The following is a description of a gene set: from publication Miyazawa M, Takashima A (PMID 22974541) Genes up-regulated in dendritic cells: 2,4-dinitrofluorobenzene (DNFB) versus diphenyleneiodonium (DPI). Identification of ROS induced genes on dendritic cells Dendritic cells were incubated for 15 min with or without a ROS inhibitor (DPI), washed extensively and incubated for 30 min with a chemical allergen (DNFB), hydrogen peroxide, and vehicle alone in HBSS containing DPI or vehicle. After washed extensively, the samples were post-incubated for 5.5 h with DNFB, hydrogen peroxide, or vehicle in complete culture medium containing DPI or vehicle. species: Homo sapiens Human Gene Set: GSE20727_DNFB_ALLERGEN_VS_ROS_INH_AND_DNFB_ALLERGEN_TREATED_DC_UP, and this is the list of marker genes: SEMA4F, SIVA1, OSBPL2, DCST2, FGF7, CIRBP-AS1, POM121L2, KRTAP22-1, LIPM, BMPR2, SELENOM, RPS8, FZD3, GGNBP2, CBX7, OR13F1, LINC00574, PPP3CA, FBXL17, SHISAL2B, AKR7A3, PASD1, SLC25A53, GUCA1B, MTCL2 (NCBI Gene Id 90072), SPART, GCNA, S100A5, NOP53, CD300LF, PTPN14, MIR99B, PLEKHH1, ACVR1C, AFG3L1P, ZSCAN25, TMEM191A, JDP2, CEP120, BCAS1, TNRC6C (trinucleotide repeat containing adaptor 6C), SPEF2, MAST4, RPL35, CD247, PDE8A, OR2A25, INPP5A, CD48, RPLP2, RPS6, IFI44, ATG16L2, JADE2, TOM1L1, EXTL2, POU6F1, MRPS25, MMP25 (NCBI Gene Id 82110), AKAP11, CDC42BPB, MYL4, EDN1, PHF6, ZNF80, ENSG00000292993, ADGRB2, MS4A1, RPS14, C3orf49, SAMD4A, HPS4, NPR2, ISCU, VMAC, MEOX1, TSPAN3, FUS, SMYD4, SLC13A1, SYDE2, CLEC4M, GPR179, KLHDC9 (NCBI Gene Id 126823), KLF9, CXCL11, PAM, AMPD3, ZNF540, ZFYVE9, GNB5, BCL2A1, RPS27, MAML2, SAPCD1, PRAMENP, TRPC1, ASB5, AMBN, ZFHX3, RORA, KPNA5, AVPR1B, CLMN, MIR130B, PROCA1, HHAT, SYT1, SPX, ST3GAL3, PHF20, GBX1, SYT12, NDP, MAPRE3, PLEKHA3, ZNF446, GPRASP1, KIF13A, LDHC, LYZL2, OR4D1, TMEM266, ENO2, TNNC2 (troponin C2, fast skeletal type), TMC1, RPS18, TPM1, GFOD1, KMT2A, SPIN3, SP110, RRAGD, TGFB3, GRPR, SLAIN2, IGFL3, AMDHD1, ZFYVE21, EEF1D, EPHB2, CAMK2N1, HERPUD2, SFRP4, CRTAP, JAM3, EGFL6, OR2Y1, ZNF354C, DLG1, SLC2A9, DDO, ASAP1, MUC16, SAV1, GPHN, HUS1B, SERPINB7, OSBPL10, SAA1, RPL13AP20, SLC25A37 (solute carrier family 25 member 37), GALNT11, HOXA2, PURA, GPRASP2, SHROOM4, RPL35A, GLS2, INKA1 (inka box actin regulator 1), TEX13A, MYBPC1, ZC3HAV1, TWF1, ZNF789, BANK1 (NCBI Gene Id 55024), TCEAL1, SPECC1L, ATP1B4, SLC5A10, GOT1L1, ZNF781, RAB39A, RPL5, PLAG1, DHX16, ZMYM1, TAS2R3, THBS2, ABCA4, HSF2BP, DLX5, C1orf141, OR1J1, BMI1, LGALS4